Given this list of marker genes Phkg2, Phka2, Phkb, Phka1, Phkg1, here is a description of the gene set: Mouse Gene Set: GOCC_PHOSPHORYLASE_KINASE_COMPLEX studied in species Mus musculus An enzyme complex that catalyzes the phosphorylation of phosphorylase b to form phosphorylase a.